Given this list of marker genes LMTK2, ITGA10, KIF1C, ADAMTSL2, PDPK1, PRKCSH, NDST1, CNTN1 (contactin 1), IGSF9B, RBM8A (NCBI Gene Id 9939), PCBP3, PTGER3, CRCP, DDX11, ZKSCAN3, CARD10, ENTREP3, DRG2 (NCBI Gene Id 1819), CNOT4, AMELX, ACKR2, FKBP15, ADAM15, GTF2F1, ZNF337, LTK, GPA33, PITPNM1, TPMT, IRF2BP1, TRA2A, FDXR, LSM12 (LSM12 homolog), WNT10B, P2RY11, SLC12A4, TCF7, ANKRD12, PPP1R10, NTSR2, GPR35, SLC22A24, CNP, IKBKG, DGCR11, MOK, PIGB, EML3, EFNA3, H6PD, KHNYN, HTR2A, IFT140, GPR161, ARSL (NCBI Gene Id 415), PNMT, PML, ADD2, ENTREP1, PAX8, HSF4, ZBED1, GSK3A, CAMK2B, CRYBA4, PKMYT1, PRPH (peripherin), PSD4, CASP2, MMP25, MYL2, M6PR, RAP1GAP2, MPP2, GPRIN2, B4GALT3, USP19, TMEM94, TCOF1, ACR, TUB, MVK, GHITM, IGHMBP2, ODF1, NHERF2, PKN2, SLC5A2, NFRKB, PTPN9, HMGXB3, PAIP2B, CYP2C9, MGAT1, SIK3, PFKFB2, PFDN1, RPA2, ORC1 (origin recognition complex subunit 1), TSPO2, NUDT3, CXCR2 (NCBI Gene Id 3579), LINC00928, here is a description of the gene set: Neighborhood of CASP2 caspase 2, apoptosis-related cysteine peptidase (neural precursor cell expressed, developmentally down-regulated 2) in the MORF expression compendium Human Gene Set: MORF_CASP2 Neighborhood of CASP2 studied in species Homo sapiens